The following is a description of a gene set: studied in species Homo sapiens Human Gene Set: GOBP_POSITIVE_REGULATION_OF_INTRACELLULAR_PROTEIN_TRANSPORT Any process that activates or increases the frequency, rate or extent of the directed movement of proteins within cells., and this is the list of marker genes: CAMK1, EP300, EMD, GSK3B, RUFY3, ANP32B, OAZ1, TMEM30A, HSP90AA1, RAPGEF3, FLNA, RIPOR1, KIF20B, UBR5 (ubiquitin protein ligase E3 component n-recognin 5, NCBI Gene Id 51366), SHH, ICE1, SMAD3, ERGIC3, XPO4, PLK3, ZC3H12A, MAPK14, VAMP2, AKAP5, ZPR1, BAG3, CDH1, TENM1, EDEM2, ECT2, LEP, MAVS, RAB29, HDAC3, SFN, RAN, TMEM30B, TPR, GLI3, PPM1A, COMMD1, CEP131, PSEN1, SLC51B, PCNT, HCLS1, ASPH, TM9SF4, CRYZL2P-SEC16B, EDEM1, TARDBP, PIK3R1, SMO, PIK3R2, IFNG, JUP, SEC16B, ZDHHC2, PRKCD, SLC35D3, PCM1, OAZ2, XBP1, ZFAND1, IL1B, CEP290, CHRM1, TRIM28, PDCD10, CTDSPL2, IPO5, EFCAB7 (NCBI Gene Id 84455), JAK2, PRKACA, B3GAT3, CD81, MDM2, YWHAE, ZIC1, CHP2, GAS6, PRP4K, PRKD1, HYAL2, CDK1, BCAP31, DMAP1 (DNA methyltransferase 1 associated protein 1), SORL1, PRR5L, OAZ3, TGFB1, SIRT6, RBM22